The following is a description of a gene set: mRNA Splicing studied in species Mus musculus Mouse Gene Set: REACTOME_MRNA_SPLICING, and this is the list of marker genes: Snrpb2, Rbmx, Snrpd2, Polr2k, Polr2a, Nsrp1, Hnrnpc, Tcerg1, Htatsf1, Snrnp48, Polr2h, Snrpe, Smu1, Ddx46, Prpf18, Eif4a3, Sf3b5, Zrsr2, Srsf1, Sf3a1, Slu7, Rbm7, Dhx15, Dhx8, Ubl5, Wbp11, Snrpd1, Prpf38a, Ctnnbl1, Gtf2f1, Polr2d, Srsf8, Nkap, BC005624, Leng1, Ccdc12, Puf60, Pcbp2, Cwc22, Bcas2 (BCAS2 pre-mRNA processing factor), Hnrnpr, Lsm2, U2af1l4, Rbm5, Ptbp1, Hnrnpa3 (heterogeneous nuclear ribonucleoprotein A3), Hspa8, Srrm1 (NCBI Gene Id 99965), Ppil2, Srsf7, Srsf9, Snrpn, Sf3b3, Rbmx2, Snrnp200, Snrpd3, Steep1, Aqr, Txnl4a, Smndc1, Rbm42, Sart1, Polr2b, Acin1, Isy1, Ppil1, Prkrip1, Fus, Fam32a, Rnf113a1, Snrnp40, Rnpc3, Magoh, Srsf5, Polr2c, Polr2g, Prpf19, Yju2, Pnn, Eftud2, Snrnp70, Ppihl, Hnrnpf, Rbm10, Snrnp25, Prpf8, Polr2l, Cwc25, Syf2, Crnkl1, Cherp, Hnrnpa2b1, Ddx39b, Ddx41, Ppil4, Sf3b2, Sugp1, Lsm5, Snrpb, Rbm8a, Dhx9, Ppih, Snrpf, U2af1, Gtf2f2, Srrm2 (serine/arginine repetitive matrix 2), Snrpc, Pcbp1, Ppwd1, Ybx1, Hnrnpd (heterogeneous nuclear ribonucleoprotein D), Tra2b, Ddx5, Ddx23, Snu13, Wdr70, Lsm8, Lsm4 (LSM4 homolog, U6 small nuclear RNA and mRNA degradation associated), Gpkow, Luc7l3, Polr2f, Cwc27, Sf3b4, Zcrb1, Lsm6, Prpf40a, Rbm22, Rbm39, Mfap1a, Prpf4, Cdc40, Srrt, Snip1, Snrnp35, Hnrnpl, Zfp830, Ddx42, Ppil3, Alyref, Prpf3, Snrpa, Cactin, Snrpa1 (NCBI Gene Id 68981), Mtrex, Usp39, Upf3b, Zmat2, Srsf11, Zmat5, Bud13, Plrg1, U2af2, Hnrnpk, Sf1, Ik, Hnrnph1, Dhx38, Sf3b1, Dhx35, Hnrnpu, Pqbp1, Ncbp1, Ncbp2, Srsf3, Phf5a, Sde2, Xab2, Dhx16, Polr2e, Bud31, Snrpg, Srsf2, Rnps1, Snrnp27, Prpf4b, Lsm7, Sf3a3, Mfap1b (microfibrillar-associated protein 1B), Cwc15, Cdc5l, Srsf10, Prpf31, Pdcd7, Hnrnpa1, Lsm3, Prcc, Sf3a2, Gpatch1, Rbm17, Wbp4, Prpf6, Rbm25, Hnrnph2, Casc3, Fam50a, Polr2i, U2surp